Given this list of marker genes IL6ST, VSIR, PTPN22, PVR, CBX7, WDR13, ITGB5, NFKBIZ, GPR148, HSPA5, KLF6, HSP90B1, DEGS1, SLA, GAA, SURF4, CREB3L2, HIP1, here is a description of the gene set: from publication Mori S, Rempel RE, Chang JT, Yao G, Lagoo AS, Potti A, Bild A, Nevins JR (PMID 18922927) species: Mus musculus Human Gene Set: MORI_EMU_MYC_LYMPHOMA_BY_ONSET_TIME_DN The Emu-myc transgenic mouse has provided a valuable model for the study of B-cell lymphoma. Making use of gene expression analysis and, in particular, expression signatures of cell signaling pathway activation, we now show that several forms of B lymphoma can be identified in the Emu-myc mice associated with time of tumor onset. Furthermore, one form of Emu-myc tumor with pre-B character is shown to resemble human Burkitt lymphoma, whereas others exhibit more differentiated B-cell characteristics and show similarity with human diffuse large B-cell lymphoma in the pattern of gene expression, as well as oncogenic pathway activation. Importantly, we show that signatures of oncogenic pathway activity provide further dissection of the spectrum of diffuse large B-cell lymphoma, identifying a subset of patients who have very poor prognosis and could benefit from more aggressive or novel therapeutic strategies. Taken together, these studies provide insight into the complexity of the oncogenic process and a novel strategy for dissecting the heterogeneity of B lymphoma. Genes correlated with the late tumor onset in the Emu-myc transgenic mouse lymphoma model.